Given this list of marker genes DEPP1, PEF1-AS1, SERP1, EXT1, ING3, ITGB1BP1, ZNF837, LINC00111, CPSF3, SH2D3C, RERE, TBC1D10B, VEZF1, SCGB1D2, ASF1B, PPFIBP2, PHF14, PRKAG2, MYO1B, SARS2, MRPS12, PLD1, FXYD6-AS1, DCAF11, ZSCAN31, OTX1, PRR13, PEF1, here is a description of the gene set: Human Gene Set: HOXB7_TARGET_GENES from publication Yevshin I, Sharipov R, Kolmykov S, Kondrakhin Y, Kolpakov F (PMID 30445619) Genes containing one or more binding sites for (HOXB7) in their promoter regions (TSS -1000,+100 bp) as identified by GTRD version 20.06 ChIP-seq harmonization. species: Homo sapiens